Given this list of marker genes SLC16A10, FKBP4, BCL11B, YIPF2, CDRT15P3, ZGPAT, FAM133B, TRAM1, ARHGAP28-AS1, ULK2, BRD3 (NCBI Gene Id 9763), GINS4, DPY19L4, ZMIZ1-AS1, POM121, UBE2Q2, KRR1, LINC00963, CCDC144BP, MCMBP, SCRN1, LSM14B, AKAIN1, DEK, IPO5, SNORD13, UBE2F, POLI (DNA polymerase iota), BAIAP2L1, RYK, CGN (NCBI Gene Id 57530), USP14, EIF3G, TMEM41A, RUSC1, GFER, EXO5-DT (NCBI Gene Id 105378672), SCRIB, MED23, DSTYK, GABPB2, CLASP2, JMJD1C, THSD4, GNG12-AS1, VANGL2, ENPP3, R3HCC1, MALT1, RBM45, TSC2, TEX38, MSANTD2-AS1, TELO2, RPP21, LGALSL-DT, TRAM2-AS1, ISM1, SNX19, CHFR, RSPH3, WASH3P, ZNF770, SNX24, STOML1 (stomatin like 1), FOXB1, INPPL1, ALKBH3, LRRC37A3, UBE4B, NDUFAB1, TACO1, ATXN1, WDR53, H6PD, ZCCHC2, TM7SF3, SLC35E2A, TRIM24, NAE1, INTS6-AS1, AP2A2, CDC25C, CBX3P2, FAM118A (NCBI Gene Id 55007), SECISBP2L, TGFB3, RPL17, PGM5P2, CORO2B, NME3, POLR2C, IRF1, PRKD3, TRADD, BRF2, FHAD1, MBTPS2, KCTD6, GRK2, AHSA2P, IQGAP2, GNG3, ELDR, RCOR2, YY1, HSPE1-MOB4, PDGFA (platelet derived growth factor subunit A), ZNF783, MAFG, SLC35A3, CNOT6, UBE2H, DLX6, PARM1, UCHL1-DT, LUC7L, ADAMTSL5, MSANTD2, SLBP, CAPN2, TOP6BL, RAB3IP, ZC3H6, PDIA4, PITHD1 (NCBI Gene Id 96276), PAXIP1, VPS37D, ALDH1A2, KCNJ2-AS1, EIF5, MBNL3 (NCBI Gene Id 55796), LYPLA1, NDUFB10, XIST, TJP3, CEBPA-DT, TSHR, SLC39A13, TCAIM, ANKS1B, SYNRG, JAKMIP2, MFSD1, SPRING1, OGFOD3, CDKN2AIPNL, PCGF2, C7orf50, SELENOH, SEMA6A, CTBP1-DT, RNA5SP456, XPO7 (NCBI Gene Id 23039), TARS2, THAP10 (THAP domain containing 10), TOR2A, SLC2A1-DT, POLE, LITATS1, EME2, ATP1B3, NOC2L, HES6, MIR1302-3, MGAT5B, PTPN2, CTNNB1, CSNK1G3 (NCBI Gene Id 1456), HMG20A, ATP13A3, DRAP1, RGL2, SRF, CTSB, CCDC88C, RNF115, RMND5B, RIPOR1, STX8, BCCIP, DEDD, GSTCD, TMEM150A, BRD3OS, GATA2, ZDHHC1, DLST, CCDC57, ADAMTS3, IKBKG, YTHDF1, SOCS2-AS1, RNVU1-27, C17orf75, MIF4GD-DT (NCBI Gene Id 100292172), MMP15, NFATC3, COL13A1, RNF217, JUND, LINC02980, PAX6, H2BP2, NAA30, C15orf39, CDKN1A, PPP1CC, SMAD3-DT, EIF2B5-DT, PET117, MED14, EIF2B5, SMARCC2 (SWI/SNF related, matrix associated, actin dependent regulator of chromatin subfamily c member 2), KDM3B (lysine demethylase 3B), ENSG00000280424, PPP6R3, RPL39P40, LGR5, LINC02709, BACH2, SYT4, FZD5, IGF2BP2, ABHD13, DONSON, ZNF608, BMP8A, ZNF236-DT, DYNC2I2, STIM2, ZKSCAN2-DT, MAPK8IP2, MINDY2 (NCBI Gene Id 54629), LCP2, VPS4A, RANBP9, IMPACT, ZNF839, MIR1538, ARID1A, CDT1, MNT, GFM1 (G elongation factor mitochondrial 1), PLCG1, MRPL38, TMEM263-DT, LRRC49, ADNP, MIRLET7BHG, BMPR1A, NFKBIA, NOXO1, VAV2, DICER1, SLC41A3, OTUD7B, CTBP2, ANKRD2, USP15, AP3M2, LINC01719, POLR2H, DDX1 (DEAD-box helicase 1), VPS13D, ADD2, STMN3, HSF2BP, MT2A, H4C4, PON2, COIL, ENSG00000232995, TAS1R1, PDXDC1, SMKR1, CYB5R3, STX18, FAM169A, SRRM2-AS1, LRFN2, ZNF775, ALDH1L2, EPCAM, TNRC6C, TMEM132B, IMPA2, WNT2B, ATPAF1 (NCBI Gene Id 64756), HSPG2, MTIF2, ITM2B, NTHL1, REXO1, TNPO1 (transportin 1), GPRC5B, INSR, NEO1, FAAP24, GDNF, PBX3-DT, ITFG2-AS1, ZNF76, EBF3, KIF26B, SPATA20, ASB6, THAP3, CD63-AS1, TXNRD2, FAM193A, C11orf68, MAP3K4, CCNL1, CLCN7, PIAS3, ABHD14B, VPS51, ILDR2, ASAP2, EEFSEC, MRPS34, IBA57-DT, ZMPSTE24-DT, AIF1L, OCRL, METTL8, OSTM1, CPQ, SIDT2, ARNT, COL14A1, NOC4L, SECISBP2, TSC22D2, NAGPA, AMOTL2, SLC39A11, EMX2, TAGLN2, SAMTOR, NEDD1, ZNF649-AS1, DBNDD2, MIF4GD, LEISA1, KCTD7, FRMD5, SORBS3, TXNDC11, H3-3A, BPTF, MANEAL, AUTS2, LTV1, SAMD11, ZNF236, GREB1L, BEND3, DLEU2, LARGE1, DDHD2, GFRA3, LIMD2, RRP1B, ENTPD1-AS1, MACF1, ADPGK, BCAR1, IRAIN, TBC1D10A, KCNC4, GNB4, NFE2L2, STX16-NPEPL1, USP39, DCUN1D2, CD63, TBC1D19, PDGFA-DT, CABIN1, OPA1, LRP6, C10orf88, PRKAB1, COBLL1, NMNAT1, GCFC2, CTR9, STEAP1, CAPRIN1, FBXO34, DGKE, SRRM2, MTF2, PTPN13, ERLIN1, SLC35B2, RCN1, UBTF, BASP1, YWHAG, DENND10, ZNF706, CST3, LRRC8C, LINC02093 (NCBI Gene Id 105371541), VPS9D1, XXYLT1, USP12, ID4, RBBP5, MARCHF3, ARHGEF12, ZEB2, RNVU1-15, ALDH7A1, DPH5-DT, PDXK, PIP4K2B, FGF9, PEBP4, PTPN11, ANKRD63, ADPRS, NBPF12, LGALSL, GTPBP3, RPRM, PTENP1, MKRN1, TCF3, XK, GTF2IP12, NTAN1, COG2, CERS6, STX18-AS1 (NCBI Gene Id 100507266), TTLL1, IBA57, ARHGAP22, RDX, KIAA0232, ABHD6, CT62, TTC21B, DNMT3B, SLC45A3, SERP1, SEC16A, ELAC1, CENPU, RNASEH2B, ELAVL1, NFAT5, GEMIN8P4, NUDT16-DT, ZNF821, EPHA4, NSD3, HACD1, MCFD2, KCNH1-IT1, CLPTM1L, SPAG7, HEXB, PAK6, FABP5P3, MYOM3, WDR47, DMGDH, LINC01385, LINC01315, ST3GAL6, SRXN1, ATIC, PPP1R3B, CFAP52, C3orf80, AZIN1, SMPD4, ACTN1-DT, FRA10AC1, LRIG3, MIB2, INTU, RANBP17, STXBP5L, METTL15, JUP, TMEM263, STRIP1, GARS1-DT, ASF1A, KIAA0319L, CPSF1, TRIM13, TFAP2A, TDRP, PSMC2, SREBF2, TXNRD1, WNT5B, APP, PRSS27, SHF, KCNC4-DT, PRSS23, TEX261, HIVEP2, ERI1, NUF2, ADAMTS7P4, SNAP91, IGFL4, AGK, LINC00327 (NCBI Gene Id 100506697), RCOR1, PGP, LARP1B, VARS2, PANTR1, UBE2E3-DT, PCGF5, DCK, TSPAN10, VSTM2L, DPH7, USP22, CLK3, ZNF503, RHCE, GNAL, NRF1, SMAD3, TCP11L1, CHD3, RFT1, RNU2-2P, MAU2, TM4SF19-AS1, GNB2, PHF19, ADRA2C, ANKRD16, UBE2F-SCLY, HTR7, SLC35E2B, WDR76, PRDM10, REST, NPW, NDE1, STX16, DMAC2L, CAMK1, AKT2, CAPN5, LSM14A, CDIP1, MEF2C-AS1, CDC42EP4, ZFYVE9, PPP1R12A, BCL7A, SENP6, MIR153-1, GFPT1, RUSF1, C16orf95-DT, KLHL9, CAD, ARHGAP29-AS1, SOCS2, RHBDF1, DGCR8, LEPROT, DTNB, OTUB2, COL19A1, ZNF786, MOB4, NKAPP1, GUSB, HEXA-AS1, SNHG12, HLTF, HEY2, PLXDC1, SNORD15A, CCDC103, HERPUD2, INPP5A, PRKAR2A-AS1, MINDY2-DT, LASP1, JAKMIP1-DT, ZNF213-AS1, WNT5A, KAT14, RNF38, RHBDD2, FAM53C, TP53I11, BMP8B, ARHGEF28, SUV39H2-DT, CDC42SE1, LRRC8C-DT, H3-3A-DT, NRXN2, RASD2, ARL8B, LINC01780, ANKS3, EPHA8, ITPK1, C11orf24, FAM47E, DCAF8-DT, TMEM187, IGHMBP2, CABLES1, ARHGAP45, GPR137C, UBE2Q1, INCA1, PCBP2, FLT4, ABCC5, SEC61A2, PKM, GABPB1, EIF4E2, MON1A, LMO2, DCAF17, BAZ2A, RFFL, RPH3AL, TAOK1, L2HGDH, DOC2A, SGO2, PTENP1-AS, TSTD2, ZNF143-AS1, ZFAND5, ZSCAN9, LEPR, SPSB4 (splA/ryanodine receptor domain and SOCS box containing 4), AGK-DT, HEXA, PPM1A, RNF170, TMC7, LMF2, B3GLCT, SMAD5, TMEM242-DT, MAPK8, GLI3, NET1, BETALINC1, PRKAR2A, QSER1, DNAJC2, SRRM3, MRPL4, CKAP4, RNF24, TSSK3, PCLAF, SLC1A4, TTI2, SDE2, BDNF-AS, KLLN, PCOLCE, ASPSCR1, ZFP69B, WWTR1, RHBDD3 (NCBI Gene Id 25807), KAT6A, HNRNPR, CRK (NCBI Gene Id 1398), FZD4-DT, TAFA2, CBFB, PDS5A, PALLD, ERCC6L2-AS1, RMDN2, LINC02851, HDGF, ANXA11, RGMB-AS1, SRD5A3-AS1, TPD52L1, PLEKHG5, ROGDI, PKMYT1, PIEZO1 (NCBI Gene Id 9780), STARD7, TOM1L2, RNF135, ATP6V1H, GPLD1, IKZF3, ZNF629, PSTK, GATA2-AS1, CLOCK, WNK1 (NCBI Gene Id 9872, WNK lysine deficient protein kinase 1), TMEM222, PTPA (protein phosphatase 2 phosphatase activator), BTK (NCBI Gene Id 695), FBXO45, GNAI1, PTDSS1, HOXB3, STUM, TP53TG5, MAP3K21, LRRC37B, HSPD1, GFUS, NALT1, NSFL1C, SARAF, HINT3, SCARB1, SMPD2, AGAP3, TBL3, RHPN2, MIR31HG, HELZ, BEND6, SHOC2, PIK3CB, SLC25A29, DOCK8, CIRBP, ACTN1, SATB2, USP45, TEAD1, TYK2, CAPN14, CHCHD6, ARHGAP12, DENND6A-DT, JMJD8, TRIM11, CCNJ, SNAP47, TCF4, ATP13A4, HSPA12A, TBL1XR1, SALL1, EN2, ADGRV1, SNORA16A, MRPS17, PKN2, ZNF143, LAGE3, MAP4K5, ZER1, MRPS6, NDUFAF1, SEPTIN7P14, TRDMT1 (NCBI Gene Id 1787), GARRE1, TRIAP1, LACTB2-AS1, CCDC159, CRBN, RCCD1, ABHD14A, MICU3, ZNF131, DDX23, ATR, S100A10, HSPE1, COPS7B, PDE6D, CCDC106 (NCBI Gene Id 29903), EEF1D, SKIL, FAAH, HLA-DQA1, ZNF521, OSBP2 (NCBI Gene Id 23762), TENT2, C17orf67, LINC02960, KIAA1958, CCT6B (chaperonin containing TCP1 subunit 6B), VPS36, MKRN2, TNFRSF10C, OLFM1, NIPBL, PPM1L, CISD3, CACNB3, DDX50, FAM3C, SIX1, RBPMS, HMGA2, PPP2R5C, ZFX, LINC02934, ROM1, SNAI1, C9orf163, PLEKHG4, STAT1, PCMTD2, MZT2B, NDUFB9, HMGN4, PLEKHM3, AURKAIP1, ADAR, SCAND1, LY6K, ENSG00000254718, EHD3, PHRF1, LZIC, SLC44A1, DNAAF8, LOXL1-AS1, AXIN2, HOXA-AS3, MIR7977, KLF6, RCOR3, JMJD4, PRKAB2, ID2-AS1, HOXD11, PRELID3A, NOXA1, COMMD2, NT5DC3, SMYD2, MCM3AP, IFI6, DHRS13, SRCIN1, C18orf21, TIMM29, COMT, KMT2A, LINC02762, SIAH2, TPH2, ANXA5 (NCBI Gene Id 308), CLUH, PPIL6, NAAA, CCDC112, PHACTR3, SNORD58A, POLR1B, EIF4ENIF1, LINC00680, TRIP4, PUM3, RBFA, CDK5RAP1, AKR7A2, IDH1-AS1, PTEN, PTPN21, SLC39A3, NSL1, PAM, SYN1, HCFC1, TIPARP, BMS1, POU6F2, MOB3A, RRP15, C8orf33, SLC12A9, RPS26, RUSF1-DT, SOAT1, ADPRHL1, NDST1, BCAR3, BIVM, NDST1-AS1, TPRA1, TYMS, VANGL1, DYRK1A, EIF3E, ELAVL2, INTS6, SMC1A, EWSR1, ANK3-DT, SLC9A1, TBC1D5, MRO, DNAAF5, MAILR, MYO5B, RTL9, GPNMB, BTBD1, MIR4634, GK5, TRIM47, TPM4, RRM2, LMBR1, DNMT3A, NSG2, TRIM3, ADCY9 (adenylate cyclase 9), KCNJ2, PRKG1, B3GALT9, PDIA6, UCKL1, ING2-DT, CSNK1G2, RNF166, STAC, SMARCD2, MTERF4, PTGFRN, FUT10, FASN, MIER2, TPI1P2, ZNF605, HSDL2-AS1, ZZZ3, EXOSC3, MIR5188, SEPTIN9, SAP30-DT, LIMCH1, DDX51, NYAP1 (neuronal tyrosine phosphorylated phosphoinositide-3-kinase adaptor 1), GPR12, INF2, ATP6V0C, PDSS1, RPL15, NKAIN2, GTF2H4 (NCBI Gene Id 2968), TRAM2, UBE2H-DT, ENSG00000223446, FBXO34-AS1, ENSG00000263280, RAET1E-AS1, DNLZ, RPN1, MKNK2, P4HA1, NHSL1, MYOF, SMIM12, SNCA, CELF2, REEP3, FBXL13, SPACA9, LEMD2, WDR74, ZMPSTE24, GPATCH2L, CENPBD1P, ZNF704, B4GALT7, CIZ1, SEC13, MAPK4, SLC12A7, SESN1 (NCBI Gene Id 27244), MRPS12, GSE1 (NCBI Gene Id 23199, Gse1 coiled-coil protein), S100A4, TTC7A, FADS3, CARHSP1, CT66, TNRC6A, CSTB, SLC25A10, GATC, SEH1L, HPS1, PTGES2, ELOA-AS1, CENPC, NR2F1, EZR, ABHD12, ENSG00000261798, CALCOCO1, EPHA3, BICD1, UNC119, CTBP1, ANKLE2, ITSN2, LINC00667, CILK1, INPP5B-AS1, DESI2, ANK3, NOP56, MAPKAPK3, GTF3C3, ARFRP1, FAM66C, CDH23, KMT5B, AP3B1 (adaptor related protein complex 3 subunit beta 1), INTS10, TPRG1-AS1 (TPRG1 antisense RNA 1), SLC66A1, NSA2, MIR9-3HG, MTUS1, UQCRFS1-DT, MARCHF8, THEM4, IFFO2, SMAD6, SYNGR2, CDK10, HOXB9, BTNL9, DENND6A, RPL36A, ARRDC1, HDDC2, GAS8, PAN3-AS1, MXRA7, UBE2E3, DCP1A, LAMP1, FXR1, SHISA4, ARHGDIA, LINC02846, MIR3190, SUV39H2, DHX8, MIR615, ATAD2B, FKBP5, ENC1, ZNF410, JAKMIP1, CYFIP2, ITGB5, ZFP62, OGT, FRS3, SGF29, POLB, APC2, NELFB, SNORD58B, NPLOC4 (NCBI Gene Id 55666), CHMP7, HIC1, LIG4, ATP11A, ATXN2L, MAML3, TEDC2-AS1, YAP1, CHTF18, ZNF205, IRS4-AS1, EP400, ATXN1-AS1, SUGP1, TXNDC16, MLXIP, TMEM129, ZFX-AS1, ZSCAN30, CELSR1, MAN2A2, HAPSTR1, LINC02029, CLCN2, CMTM7, MTF1, PPP1R13B-DT, CDC42SE2, TIGD1, MIR4674, DSC3, KCNMA1, CITED2, ERN1, AFG3L1P, CHCHD4, PLEKHO1, BTG3, SIAH1, PSMG3-AS1, DNAJC6 (DnaJ heat shock protein family (Hsp40) member C6), PDE8A, ZNF185, PRRT3-AS1, RPS29P16, MIR29B2CHG, EXO5, NOM1, CD55, FRG1, CCDC88C-DT, MAFA, FAM174C, MIR4672 (NCBI Gene Id 100616429), GABPB1-AS1, IDH2, GRAMD1C, FBXL21P, CARHSP1-DT, ZNF251, ABHD14A-ACY1, BASP1-AS1, RSAD1, EPB41, TNPO3, MIR3613, MFSD6, ERCC6L2, RPL37, HERPUD2-AS1, PDK3, HEBP2, TMEM70, FBRS, SUMO2, HEXD (NCBI Gene Id 284004), STUB1, MRPS31P5, TMEM242, ZNRF2P2, CERCAM, MSX1, MIR661, GCN1, TFDP1, NDST2, PTPN11P3, CEP57L1, CHRNA3 (cholinergic receptor nicotinic alpha 3 subunit), AARS2, LINC02166, CDK17, LINC01775 (NCBI Gene Id 101928602), BBIP1, STRADB, C7orf25, G2E3, APP-DT, PAN3, CHROMR, FGFR1, RPS17, PPIA, TES, SEC24B, ALG5, DYNC1I2, RIBC1, CTCF, VSIR, CFAP410, BOLA3-DT, SGMS2, ASS1, TFAP4, SLC25A6, TMEM121 (transmembrane protein 121), TSEN15, ACAT2, MRPL58, DNAJC5, SETD2, EXD3 (NCBI Gene Id 54932), EIF3F, LINC01547, TAB2, KCNQ5, ZMIZ1, AFF3, CYBRD1, SENP5, LIMD1, MAPK8IP1, SF3A3, ATL1, FLOT2, NAV2, NCAPG2, WDFY3-AS2, DPY19L1, DHX30, GOLGA3, BATF3, RPS4XP16, MARK4, NIPSNAP2, USF2, ARID2 (AT-rich interaction domain 2), LPIN1, ZNF264, PIGO, SELENOOLP, UBE2I, TEX30, DUSP22, CHSY1, PXMP2, SPOCK1, JADE1 (jade family PHD finger 1), PLD6, DPH5, UBE2J2, MAGEF1, ITPR3, FOXN3, KCTD15, ULBP1, PPP1R13B, TOPBP1 (NCBI Gene Id 11073), RPL36A-HNRNPH2, SAP30, FBH1, CTU2, CTNNAL1, RBMS3, NCDN, EFNB1 (ephrin B1), BCOR, FAM200B, INHCAP, YAF2, TRPC4AP, TNIP2, PCID2, OTUD3, USP25, SEPHS1, PTGR3, ZNRF2, ZKSCAN2, TXNL4A, ZNF276, PSMD14, FOSL1, NR3C1, BSCL2, FBXO9, EPB41L4B, SQSTM1, MARCKSL1P2, FASTK, SFXN1, PITPNA, ZNF892, JPX, RGS7, NUDT6, NDUFS7, ERLEC1, NADK2, CFAP206, SSBP2, BMI1, ZNF271P, METTL5, MAP7-AS1, NTN3, BICDL1, UBXN2A, TLNRD1, NOTCH1, EXD2, ZNF598, TOB2, DIDO1, ING2, MIR193A, ATG14, SLC38A1, SCARB2, CNP, PLPP5, RNA5SP283, PRDM4, CLPB, EN2-DT, DMAP1, IGF2BP3, QKI, TPPP, SKIDA1, ATG13, ZSCAN25, POLR2A, SCAMP1, MGAT1, PPP6R1, CRLF3, AIG1, SMIM10, LATS2, SUZ12P1, UNC13A, KIF1C (NCBI Gene Id 9713), ULK3, TMEM43, DHRS3, FAXC, WDR24, SLC1A1, DLC1, MRPL21, TWF1, SLC20A2, FAM187A, FBXL17, USP10, SNRK, ANO8, CCAR2, THBS1, GCLC, TBCD, ZC3H12A, FBXL3, DECR2, PRKD3-DT, ZNF318, TMCC2, IMPDH1, TUBB3, ZSCAN16-AS1, MRPL39, VPS16, ZNF326, NPTX1 (NCBI Gene Id 4884), MARCHF10, RPL6, PTOV1-AS1, DUSP13B, GARS1, MTRFR, LINC02939, PITPNC1, PTMA, COPS9, RNF138, HOXD8, NCOA2, PCED1A, PAXIP1-DT, LINC02593, TDRD7, CEP89, MPHOSPH9, ISOC1, CAMLG, MAPK10 (mitogen-activated protein kinase 10), CAMK2G, ARL5A, CEBPA, HEG1, PPHLN1, CUX1, SMAD2, TPM1, MINCR, PFN4, MPP7-DT, FZD4, ACIN1, LINC01159, RAB11A, FER1L6-AS1, HTR5A, UROS, PBX3, ACTB, NKIRAS1, EDC4, GAN, GCLM, KRBOX5, SLC39A14, PAQR4 (progestin and adipoQ receptor family member 4), RRP1, BCYRN1 (brain cytoplasmic RNA 1), PEAK1, COMMD1, SCN8A, GLDC, FBXL5, PRRT2, PPIP5K2, VKORC1L1, TRAK2 (NCBI Gene Id 66008), SYNJ2, CCDC102A, METTL9 (methyltransferase 9, His-X-His N1(pi)-histidine), PXK, ZNF609, NOL9, CLIP2, TFRC, PARP12, DOCK6, RAPGEF3, COMTD1 (catechol-O-methyltransferase domain containing 1), MAP4K4, CCDC7, RNF11, EPB41L3, DHRS7, DDX55, ADIPOR1, ADSS1, CLN6, ENSG00000247131, ALG6, EXOSC6, KRT8, NOC3L, ZNF395, FTCDNL1, FXN, DDX18, SUDS3, ARHGAP28, KCNH1, DNPH1, SAV1, UXS1, RPS7, COQ8B, MTFMT, TRABD-AS1, FAM228B, MELTF-AS1, GDNF-AS1, ATP13A3-DT, FOXC1, G6PD, TARBP1, ID2, GIN1, KCTD18, MINAR1, RPUSD1 (RNA pseudouridine synthase domain containing 1), AFF1, FOXK2, HARBI1, E2F3, ZBTB4, PLCB4, EML3, PFKFB3, SEPTIN5, ANKRD40, PHLDA3, LIN7C, PPM1L-DT, SEMA3D (semaphorin 3D), RCCD1-AS1, MYO1B, TSHZ1, SRSF3 (serine and arginine rich splicing factor 3), MREG, AFG2A, DDX11L5, MILIP, DDX11L10, ASB3, IDH2-DT, TBC1D13, ZBTB21, TMCO3 (NCBI Gene Id 55002), PBX1, MTHFD1L, POU2F2, MDM2, POLR3C, STMP1, DNAJC11, DOCK5, PTAR1, WDR36, GEMIN7, ZBTB7C, ENSG00000293341, TRIM67, ENGASE (endo-beta-N-acetylglucosaminidase), SEMA3C (NCBI Gene Id 222200), PSMG3, DEF8, DPP9, EMX2OS, YBEY, NBPF19, GCSH, RHOT2, SELENOO, MCUB, SLC25A51, INTS1, FOXRED2, IL18R1, TACC3, EEF1A1P23, MTERF3, MIR3663, PPP1R37, TOP3B, B4GALT4, SCAMP1-AS1, ABI2, NDUFC2, RGS5, FOXD3-AS1, RRN3, CDK14, SLC12A2, SAMD4B, COQ5, SELENBP1, GASAL1, NCBP1, ELAPOR2, LHPP, BARHL1, DICER1-AS1, ZNF579, CARD19, SPRED2, IRS4, ERC1, CFAP77, MRPS31, SP3, CRTC1, SLC37A3, FAM43A, C2orf88, RCN2, SPECC1P1, AP5S1, ARHGEF11, AP4E1, RERG, CSPP1, DUS1L, WRNIP1, EFCAB14, MIR4500HG, FRG1-DT, PSMF1, ZNF398, ESYT1, KAT2B, DST, ANKRD20A4P, RESF1, PTOV1 (PTOV1 extended AT-hook containing adaptor protein), INPP1, SYDE2, GASK1A, MIOS, METTL21A, ALDH1L1, CT75, TATDN1, FADD, ENSG00000245025, PTK7, MIR3188, ARFGAP3, KCTD8, PPP3CA, RXYLT1, TPD52, VPS37B, NUDT19-DT, TET3, SH3BGRL2, SLC12A2-DT, PLPP6, ALG1, FSTL3, ELOVL6, CORO7, RASD1 (NCBI Gene Id 63428), VPS25, KMT2C, MEMO1, DOCK7-DT, DNM1, ADCK5, DOCK7, LINC01140, ZNF593 (NCBI Gene Id 51042), IDH1, PRICKLE2, SIK2, MIOS-DT, PEX10, CBX4, EGFEM1P, RPS3, SERP2, RNPEP, H1-0, ARHGAP44, NCAPH2, FBXW2, GALNT16-AS1, ANAPC4, ELL3, GLIDR, PIGO-AS1, RAD52, FHL2, LINC01359, ABL2, ZNF503-AS2, USP30, INPP4B, PTPN18, RPL17-C18orf32, KLHL17, MIR4515, MEF2C, IL17RC, GFM2, RPRML, HS3ST3A1, LRIG3-DT, ACACB, MRPL12, LUZP1, SLC5A3, ZDHHC4, ZBTB34, GRM8, SRPK2, LRRD1 (leucine rich repeats and death domain containing 1), PCAT14, EFTUD2, AMOTL1, CYREN, ZNF577, PBLD, AAAS, SLC66A2, EEA1, UBC, C5orf24, FBXO22, CUL4A, CBX3P4 (NCBI Gene Id 100873792), RAB11FIP5, CFDP1, FGF19, MARF1, BCAP29, SMIM2-AS1, RERE, MTG1, AP3S2, SNAP25-AS1, BDKRB2, LTBP3, CH25H, XPOTP1, PIM1, SERPINE2, ZSCAN12, PRDM11, TRIM36, SMAD7, ANTKMT, BOLA3, ZFP30, C8orf88, LEF1-AS1, COPS5, ADAP2 (ArfGAP with dual PH domains 2), SNHG17, HMGB1, NFKBIZ, ARF1, INTS12, ETV3, CDC20B, GRIK4, ISLR2, ATP8B1-AS1, TP73-AS3, DDI2, ST3GAL6-AS1 (ST3GAL6 antisense RNA 1), ZNF23, MAZ, CLTB, UBE2D2, GREB1L-DT, SBF2-AS1, ATP11B-DT, EEF2K, CTCF-DT, DHFR, LSG1, ADGRL1, NCOA5, ARMC10, PYGL, IL12A-AS1, PLEC, SYNM, MARVELD2, LINC02981, IQSEC1, SH3GL1, C4orf36, B3GALT4, ZNF767P (NCBI Gene Id 79970), IZUMO4, MSH3, PHIP (NCBI Gene Id 83843), SARS2, TATDN3, MIDEAS, STK3, RNU1-38P, SLC41A2, RNF19B, NDUFC2-KCTD14, FZD1, GALNT2, SMG8, DUSP16, RNF130, BNIP3, TEFM, PTGES2-AS1, EFR3B, PSMD14-DT, SLC35G1, SLX9, MNS1, NUDT19, here is a description of the gene set: Genes containing one or more binding sites for (ZSCAN30) in their promoter regions (TSS -1000,+100 bp) as identified by GTRD version 20.06 ChIP-seq harmonization. studied in species Homo sapiens from publication Yevshin I, Sharipov R, Kolmykov S, Kondrakhin Y, Kolpakov F (PMID 30445619) Human Gene Set: ZSCAN30_TARGET_GENES